Given this list of marker genes GPD1, HADH, HADHA, PARP9, IDH3A, CTBP2, NNT, LDHB, CRYL1, ME3, SIRT6, SIRT5, ALDH1B1, IDH3B, IDH3G, CTBP1, ALDH2, GAPDH, GAPDHS, SIRT3, PARP14, SIRT4, ALDH1A1, PHGDH, SIRT2, BDH2, HSD17B8, CRYZ, IDH2, NUDT6, NDUFV1, IDH1, HSD11B2, ME1, GLYR1, PARP15, GRHPR, NDUFS2, EHHADH, ALDH1A3, SIRT7, SIRT1, QDPR, PARP1, ME2, GLUD1, UGDH, HPGD, GPD1L, ZC3HAV1, AOX1, UXS1, ADH4, SORD (NCBI Gene Id 6652), HIBADH, RNLS, here is a description of the gene set: species: Homo sapiens Binding to nicotinamide adenine dinucleotide, a coenzyme involved in many redox and biosynthetic reactions; binding may be to either the oxidized form, NAD+, or the reduced form, NADH. Human Gene Set: GOMF_NAD_BINDING